The following is a description of a gene set: part of: Diseases of nucleotide metabolism Reactome Pathway: Nucleotide catabolism defects Purine nucleotide phosphorylase defects are annotated here. species: Homo sapiens, and this is the list of marker genes: PNP